Given this list of marker genes RAB5A, RPL17-C18orf32, ISLR2, SLC35D1, NUF2 (NCBI Gene Id 83540), LMBR1, ENC1, VPS37A, MATN1, CD68, TLL2, BBS9, GLYCTK, NUP50, NSA2P4, EID1, MLLT1 (NCBI Gene Id 56930), IGF1R, POLG, ATPAF2, ALG1L1P (NCBI Gene Id 200810), NR2F1, FAM227B, CNPY2, HMGCR, NHP2, SNORD13, RNFT2, MCM7, LARS1, INHA, ENSG00000272008, ID2, NDUFAF7, OGA, KPNB1, LINC01843, VNN3P, RBM47, C15orf40, CPD, RNU6-599P, DCAF6, PUM1, FAM185A, CMC2, DVL2, C2, LTBP1, TNS1, STX6, NUP50-DT, PPP5D1P, PCK1, PSMD1 (NCBI Gene Id 5707), RASSF5, TBX2, APLF, GLA, RPL34, RNF138, OSBPL6, CDV3, N4BP1, FBXO48, SKA3, DAPK3, EPB41L4B, EVI5L, MRTFB, CENPA, LAMP1, SLC25A28-DT, SH3YL1, CAPRIN1, TTC39C, PHF5A, GFM1 (NCBI Gene Id 85476), SON, USF3, MIXL1, BABAM2, TMC8, ITFG2, TTI2 (TELO2 interacting protein 2), WDR75, SLC25A36, SPATA2L, DHODH, INTS13, TMEM209, RFX5, TCIRG1, COPB1, SAMD4B, SERPINA11, PPP4R3B-DT, EXOSC3, PPP1R11, SNHG16, SOX8, P4HA2, INTS6-AS1, LTV1, EMC2, PLEKHG2, LINC00511, PICALM, C1orf43, RPL34-DT, PSMD9, MBL2, SLC22A11, PLEKHJ1, SECISBP2L, CEROX1, SPTBN4, MIEF2, UBALD2, RSPRY1, HNRNPD, FOXN3 (NCBI Gene Id 654111), RC3H2, BLVRB, MAPRE2, CLEC16A, MEA1, MAT2A, TIPARP-AS1, AKAP1-DT, NEMP1, BAG6, DHTKD1, OSBP, PTGES3, RPS11, POLR2L, LRP6, ABHD2, CCDC146, DRAIC, TTC27, ZNF827, ENSG00000227496, TARS2, NME6, RBM23, FEM1B, TMEM177, GID4, AXIN2, USP1, H4C1, ENSG00000199566, MYL12-AS1, LRIG1, SRSF11, TMEM248, ZNF516-AS1, CYP51A1-AS1, EIF4EBP3, LIMK2, RFX1, SHFL, TBX2-AS1, UBAP2L, CCT5, DRC3, DICER1, FCSK, SWAP70, PTCH1, PDE12, PTP4A2, ITGB5, LINC00957, PYGL, WASHC2C, NOP14-AS1, MYO9B, EIF2S2P5, DCTN1, STK32C, POLG-DT, ID1, PIGL (phosphatidylinositol glycan anchor biosynthesis class L), SORBS2, USP32, H2BC10, ENKUR, DAPK2, PER1, ENSG00000232995, PLD3, DGAT2-DT, ATG3, HSPBP1, NRP1, MET (MET proto-oncogene, receptor tyrosine kinase), WDPCP, SEC22C, PER2, LINC02365, HSD17B12, ENSG00000239137, EFTUD2, AADACP1, MAML1, DNAJB5, GLYCTK-AS1, ANKS4B, OBSL1, AKAP1, GLTPD2, RPL27, KCTD9, FAM187A, CBR4-DT, MDH1, DICER1-AS1, RBL1, MLLT10, ZFP91-CNTF, MRPL48, ARSK, LEMD3, PRKCI, NAT9, GPRC5C, VPS33A, MTND4P7, AURKA, DNAJB5-DT, N6AMT1, DAXX, PGK1, CIDEC, HSP90B1, CNOT7, YPEL5, JMJD1C, GRB7, TPP1, HMGB1P8, AJUBA, CFAP20, SPIN2B, NFATC2IP, RPS25, ARSB, CNPPD1, ARRDC4 (arrestin domain containing 4), NAB2, UBC, DAGLB, PPP2R5A, ATG12P1, ZNF337-AS1, PRXL2A, TUBGCP5, GLS2, DARS1-AS1, RBM15-AS1, LINC02960, TRIP4, CFDP1, PIK3R1, RASGRP3, RNU5E-1, PRRC2A, MPV17L2, HSD11B1L, CUTA, UNC93A, ANKRD13A, HPS5, AARS1, BUB1, ZNF687, RPL39P40, LINC03037, EGOT, NBR1, CKAP5, C7orf57, CCDC71L, WDR62, ITPA, GPHN, ZNF292, ACYP2, GTF2B, USP36, PPP1R10, PBX3, DOCK4, SEMA4C, EML2, H3C8, CCDC103, AJUBA-DT, TTC28, MEF2C, ATP9B, ZNRD2, MRPS18B, PIM1, LIN54, AK2, ILF3, RBM39 (NCBI Gene Id 9584), CBX3, EIF2B4, EPCIP-AS1, PUS10, MEMO1, TIMMDC1-DT, GRK6, ITGB3BP, SLC25A26, CALM3, MBD5, WDR11-DT, DNAJC16, DARS1, WBP11, CLCN3, CCDC192, RPL36, C12orf60, SLC25A28, RAB3GAP2, GTF2H1, CTNNA1, FCHO2, MAPDA, TNPO2, PIWIL2, ZNF473, SNX16, TPM1, DYRK2, CCAR2, NXN, RBX1, CLK4, CHCT1, NKD1, HUWE1, FAM21EP, KPNB1-DT, ERCC1, HOXA-AS3, VPS13B, LINC01101, PHF12, TFRC, FMC1, ANKRD1, RGN, TBC1D19, PDE7A-DT, TCF3, BRPF1, USP3-AS1 (NCBI Gene Id 100130855), NCOA2, LYRM7, TRIM44, SNORD58B, RAD9A, ZNF277, MIR375, CCDC66, CAND1, GCFC2, FGFR1OP2, VIRMA, TFPT, EHMT1, MFSD3, MRPS15, PWWP2A, STK40, MANF, P4HB, SYBU, CEP104, CLDN4, DOHH, LCMT2, SEPTIN7P14, RBM3, TBC1D22A, TMEM44, WASHC2A, SLC9A1, RPS6KA1, PKD1L2 (NCBI Gene Id 283928), ZNF84, CEBPZ, TRA2B, MAP7, SKIC3, ELAC2, DYNLT4, POR, CAB39L, SLC45A4, CXCL2, MIX23, NDUFS7, FZD3, TAF1D, PIPOX, GNB2, RASA4CP, KLHL28, CSTF1, BMAL1, RPL17, LMF1, EFNA1, ZNF217-AS1, ZNF563, PRDX1, ENSG00000270571, RN7SL635P, CYP51A1, EIF2AK4, UBE2B, ZNF84-DT, VRK1, NSUN3, LINC01900, CDK12, LRRC27, MIR3189, ATAD3A, TOM1L2, UBE2V2, L3HYPDH, RRAGC-DT, CPLX2, NDC1, ENSG00000224090, CFAP68, ZW10, EIF3D, ENSG00000268460, ADRA1D, HNRNPD-DT, RRAGC, SLC38A6, TRIB1, RAP2B, CYCS, VRK3 (VRK serine/threonine kinase 3), DOLPP1, ZNRD2-DT, PXMP2, MMAB, PDCD6IPP2, TRIM47, RBKS, CAPZA2, NANOS1, PPP6R1, RPL22, GTF2IP12, FMC1-LUC7L2, SARM1, KANSL3, HNRNPA2B1, CDC20-DT, MAST4, SLPI, LINC03064, CRY2, DHPS, PLEKHB2, BTD, MIR4437, SMARCAD1 (SWI/SNF-related, matrix-associated actin-dependent regulator of chromatin, subfamily a, containing DEAD/H box 1), TRAPPC12, F11R, H2AC10P, CALM2, SF3A2, SEPTIN7P13, TBC1D25, ADAM9, ZC3H6, ZSCAN2, DGKE, CCN2, BMF, PPM1H, TRIP12, STYX, SRRT (NCBI Gene Id 51593), ACO2, ARHGEF37, FAM216A, SF3B1, C19orf48P, ERAL1, NR1D1, C9orf72, DNAJB1P1, CRB1, CCT8, PPP4R3B, TIMMDC1, ERBB2, TRABD2A, GAS8, CCT6A, ALDOA, BDH1, FDXACB1, FAM21FP, FAM222B, NDUFAF5, PGAP1, CHCHD3, CENPU, SUFU, G3BP2, SLC35A5, SLC25A32, UBE2Q1, RCL1, AHNAK, SNORD118, GATAD2A (NCBI Gene Id 54815), ITFG2-AS1, HEXA-AS1, PBX3-DT, GOLM2, DCTN4, SERPINB9P1, MYL12B, SPRING1, RAB7A, NR2F1-AS1, SRI, TMEM218, RPS14, SLC29A1, UBE2I, RIN1, GTF2IP20, GFI1B, ACSL6, ATPSCKMT, DHFR2, EFHB, PDE7A, ANXA2, TYW5, CDC20, SDAD1, HAUS8, RUVBL1, FAM3D (FAM3 metabolism regulating signaling molecule D), TMEM170A, SORD2P (sorbitol dehydrogenase 2, pseudogene), CSNK1G1, KCNIP2-AS1, ABHD16A, TLCD3B, PPP1R1B, MTF2, OLFM1, LSM8, SCAP, BRWD1, TSC1, IFNAR1, EIF4B, ATP10B, WDR37, SETDB2, ARF3, RNF6, PDPR, DNAAF3, TTC32, RPGRIP1L, ESF1, UBB (ubiquitin B), SPRY1, SH3RF2 (SH3 domain containing ring finger 2), RMND5A, TNFAIP3, PTBP1, TDRKH, SPCS1, ARHGAP5 (NCBI Gene Id 394, Rho GTPase activating protein 5), MPC2, BBOX1, PSPH, EXOC3L4, UPF3B, PFDN4, NANP, RETREG2, LRRC49, STN1, GDF15, RNU6-92P (NCBI Gene Id 106479607), PSME3IP1, CACYBP, AP4M1, ZNF419, MIR1302-3, TMEM65, AURKB, DFFB, HNRNPH2, KAT5, EIF4A2, IRS1, LGR4, GTPBP6, POLRMT, SSR3, ORC4, RITA1, MEAF6, LRRC40, PIP4P1, C17orf67, UGP2, ILF3-DT, MIR300, GSK3B-DT, SMG7-AS1, ZBTB40, RRAS2, KLHDC3, KIAA1217, PPP2R5C, PRMT5, CHN2, SSR4, TCFL5, SLC39A11, HCG14, SLC33A1, CUX1, FTO, ATP2B4, PHKA2 (NCBI Gene Id 5256, phosphorylase kinase regulatory subunit alpha 2), CCNT2, TBL1X, FUT5, SYT7, IDH3G, ADGRL1, GPN3, MAIP1, DGAT2, SMG7, CNPY2-AS1, FEM1A, RASGRF1, MIR548AW, TTC41P, MIR762HG, KRTAP3-1, WDR11, SETDB1, TMEM104, ZNF516, RPS26, WDR27, RDH12, CS, VCP, SNX1, NKTR, TTC3 (tetratricopeptide repeat domain 3), PLK3, ARSF, MAST4-AS1, PAXBP1, SNX17, GPBP1, ERCC5, DNLZ, AP5Z1, RGS5, KLHDC9, FBXO36, GOLGA8A, HECTD1, C19orf47, MVK, ECD, FAM149B1, KCNQ1OT1, PRPF31, THAP8, C6orf120, TAOK1, POLE, TOGARAM1 (TOG array regulator of axonemal microtubules 1), SP5, SIRT4, SLC7A6, TASOR2, BANP, MCPH1-AS1, LCAT, SSUH2, ANAPC5, ZSCAN26, LUC7L2, CDKL3, FBXO38, LPXN, BTBD19, METTL25, SLC28A2-AS1, DTWD1, ERGIC2, TSPAN4, DCAF13, FAM185BP, CSNK1A1, NFIC, SMARCAD1-DT, MIR4519, RAB10 (RAB10, member RAS oncogene family), TSPAN1, TTC32-DT, FAAP20, GPI, PCLAF, TMEM72, VIRMA-DT, UQCRC2, RBSN, MRPL57, LRRC7, CTNNA1-AS1, CLPTM1, GABARAP, RAB5IF, HID1, MIR5188, KIAA0319L, PRMT5-DT, ASGR2, CFAP74, MAPK14, TBX3, WSB2, TDRKH-AS1, MARCHF8, DDX19B, VPS13B-DT, ANKLE2, MICOS13, PNISR, PDK1, TRAPPC4 (NCBI Gene Id 51399), AP3M2, CCDC59, ARID2, RAD1, SORT1, SLC25A25, FUS, HEXA, PRSS48, CDCA2 (cell division cycle associated 2), RNASEH2B, CDK4, RFC2, STIP1, HEG1, LOX (NCBI Gene Id 4015), SRCAP, LINC-PINT, ZFP91, ETS2, UGT2B7, ABCD3, MAN2C1, CCNT2-AS1, PMPCB, KDM4A, TIPARP, FABP1, LINC02363, SHC4 (NCBI Gene Id 399694), NUDCD3, HACL1, SMG6, KLHDC10, HMGCS1, INTS6, DCUN1D4, TAF1, ZDHHC18, HAL, NUBP1, LINC01124, FOXJ3, FAF2, CRIPTO, EFL1, AP1AR, CASP9, HISLA, ILVBL, RPL38, NAGK, FGF14, FAM220A, RNF10, LINC02453, here is a description of the gene set: species: Homo sapiens from publication Yevshin I, Sharipov R, Kolmykov S, Kondrakhin Y, Kolpakov F (PMID 30445619) Genes containing one or more binding sites for (TBX3) in their promoter regions (TSS -1000,+100 bp) as identified by GTRD version 20.06 ChIP-seq harmonization. Human Gene Set: TBX3_TARGET_GENES